The following is a description of a gene set: The gene expression program underlying the specification of human cell types is of fundamental interest. The study authors generated human cell atlases of gene expression and chromatin accessibility in fetal tissues. For gene expression, the study authors applied three-level combinatorial indexing to >110 samples representing 15 organs, ultimately profiling ~4 million single cells. The study authors leveraged the literature and other atlases to identify and annotate hundreds of cell types and subtypes, both within and across tissues. Our analyses focused on organ-specific specializations of broadly distributed cell types (such as blood, endothelial, and epithelial), sites of fetal erythropoiesis (which notably included the adrenal gland), and integration with mouse developmental atlases (such as conserved specification of blood cells). These data represent a rich resource for the exploration of in vivo human gene expression in diverse tissues and cell types. Marker genes curated from the annotated cluster as represented in the Descartes Human Gene Expression During Development database. Human Gene Set: DESCARTES_MAIN_FETAL_MUC13_DMBT1_POSITIVE_CELLS from publication Cao J, O'Day DR, Pliner HA, Kingsley PD, Deng M, Daza RM, Zager MA, Aldinger KA, Blecher-Gonen R, Zhang F, Spielmann M, Palis J, Doherty D, Steemers FJ, Glass IA, Trapnell C, Shendure J (PMID 33184181) studied in species Homo sapiens, and this is the list of marker genes: LINC01641, LINC02810 (NCBI Gene Id 107984028), TCP10L2, TMPRSS15, CYP4F12, PDZPH1P, RTP4, DPPA5P4, PLS1, RPS3AP5, ARHGEF34P, TRIM31-AS1, OCLN, MRO, HNRNPA1P54, TM4SF19-AS1, SDCBP2, SLC28A2, RPS4XP11, ZNF774, ESPNP, DMBT1, SLC25A30-AS1, LINC01595, GDF9, GDA, CYP2C19, LINC01856, UBE2V2P1, ASZ1, TRPC7-AS1, LINC00319, POF1B, RPL27AP, LRRC19 (leucine rich repeat containing 19), RNU6ATAC39P, BEST4, EPCAM, AGPAT2, TRIM31 (tripartite motif containing 31), PLA2G4E, RPL28P5, GALNT4, PWP2, PDE4C, GPA33, UST-AS2, LINC01976, MMP1, MROH3P, OTOP3, MUC3A, GCSHP3, PABPC1P4, GK-AS1, ZC3H12B, ARHGEF2-AS2, LINC02453, RPL34P33, TCP10L3, NKX6-3, S100G, BCAN-AS1, OCIAD1-AS1, AKR1B10, PLCE1-AS2, MIR3648-2, LINC01924, INAVA, RNU6-1093P, PRR15L, PREP, HPN-AS1, TM4SF20, RPL8P4, SLC3A1, MUC7, RPL12P13, RPL21P1, RN7SL404P, ITPK1-AS1, NQO2-AS1, ENPP7P8, SLC19A3, ENSG00000229261, CHST5, MIR194-1, INO80-AS1, TSPAN8, LINC02901, KRT20, RPL31P2, MXD1, H4C16, NMUR2, RHPN2, LINC01979, TSGA13, CYP2C18, CYP2B7P, RPL3P2, FMO4, OOEP-AS1, ZNF653, FER1L6, RN7SL448P, TLCD2, ODC1-DT, ZNF443, ENSG00000255367, CEACAM5 (CEA cell adhesion molecule 5)